Given this list of marker genes Mif-ps8, Rpl7l1, Gm18067, Kpna2-ps, Trem1, Polh, Ptk7, 5830444F18Rik, Gm4946, Bicral, Gm9586, Rftn1, Tbcc, Mark1-ps2, Tomm6, Srf, Plcl2, Oard1, Gm4471, Slc5a7, Gm20596, Cul7, Gm41584, Gm46574, Guca1b, Ptcra, Kif6, Mad2l1bp, Ubr2, Gm32055 (NCBI Gene Id 102634480), Gm16555, n-R5s28, Tpt1-ps7, Mrps36-ps1, Frs3, Gm9214, Bysl, Mrps10, Gm9706, St6gal2, Klc4, Yipf3, Guca1a, Daam2 (NCBI Gene Id 76441), Pp2d1, E430014B02Rik, Gm18735, Klhdc3, Polr1c, Nfya, Foxp4, Rrp36, Gm19585, Lrrc73, AY702103, Sgo1, Gm16494 (NCBI Gene Id 105246356), Gm36200, Kat2b, Trp53-ps, Efhb, Gm9191, Mark4-ps, Gm25177, Rsph9, Gm22978, Ckb-ps2, Cnpy3, C330011F03Rik, Gm31532, Ccnd3, Tspo2, Gm6934, Tfeb, Mdfi, Frs3os, Gm24071, Gm26291, Hcfc1r1-ps2, Mea1, Mir693, Adgre4, Trem3, Gm17830, Usp49, Rab5a, Apobec2, Gnmt, Treml2, Sult1c2, Gm5814, Mrpl2, Mrps18a, 1700008K24Rik, Gm18365, A730006G06Rik, Crip3, Zfp318 (zinc finger protein 318), Mocs1, Gm5094, Ckb-ps1, Dazl, Gm6919, Tbc1d5, Xpo5, Gm9224, Gm5684, Gm18679, Pex6, Pgc, Gm9210, Dlk2, Gm46577, Gm7334, Trem5, Unc5cl, Kcnh8, Gm27217, Gm5093, 1700025K24Rik, Treml1, Gtpbp2, Dnph1, Vmn2r118, Prickle4, Gm31143, Satb1, Gm41600 (predicted gene, 41600), Sult1c1, C230085N15Rik, Cimip3, AI661453 (NCBI Gene Id 224833), 2310039H08Rik, Gm35692, 1700122O11Rik, Gm41597, Pot1b, Gm29770, 4932415M13Rik, Gm4945, Gm19969, 1700067P10Rik (NCBI Gene Id 68224, RIKEN cDNA 1700067P10 gene), Trem6l, Gm25201, Tomm6os, Trem4, 4930542M03Rik, Mark1-ps1, Ttbk1, Abcc10, Tjap1, Vegfa, Mir6976, Treml4, Gm22654, Gm22474, Hcfc1r1-ps1 (host cell factor C1 regulator 1 (XPO1-dependent), pseudogene 1), Slc22a7, Rab5a-ps, Gm19465, Gm19197, Med20, Gm20517, Prph2, Gm20098, Lrfn2 (leucine rich repeat and fibronectin type III domain containing 2), Ppp2r5d, Gm18648, Trem2, Trerf1, Taf8, Cul9 (cullin 9), here is a description of the gene set: studied in species Mus musculus Mouse Gene Set: chr17C